The following is a description of a gene set: Catalysis of the reaction: triacylglycerol + H2O = diacylglycerol + a carboxylate, where the triacylglycerol is part of a lipoprotein. May also hydrolyze diacylglycerol and phospholipids present in lipoproteins. studied in species Mus musculus Mouse Gene Set: GOMF_LIPOPROTEIN_LIPASE_ACTIVITY, and this is the list of marker genes: Apoa5, Pnliprp1, Apoc2 (apolipoprotein C2), Lpl, Pnlip, Gpihbp1, Apoh, Lipc, Lipg, Apoc2l, Pnliprp2, Dagla